The following is a description of a gene set: studied in species Mus musculus Mouse Gene Set: GOBP_NEGATIVE_REGULATION_OF_PHOSPHATASE_ACTIVITY Any process that decreases the rate or frequency of phosphatase activity. Phosphatases catalyze the hydrolysis of phosphoric monoesters, releasing inorganic phosphate., and this is the list of marker genes: Hpn, Tmem132c, Epm2a, Chp1, Tnf, Uri1, Bag4, Tmem225